The following is a description of a gene set: studied in species Homo sapiens Human Gene Set: MODULE_141 Genes in the cancer module 141., and this is the list of marker genes: SLC12A3, SLC12A2, FXYD3, GLRA1, CLIC2, VDAC1, GABRA6, GABRG2, GABRA1, GLRB, GABRA5 (gamma-aminobutyric acid type A receptor subunit alpha5), GLRA2, SLC34A1, SLC26A3, GABRA2, CLCNKA